Given this list of marker genes ATP1B2 (NCBI Gene Id 482), DLG1, MIR103A1 (microRNA 103a-1), ATP1B3, STK39, MIR26A1, MIR30D, ANK2, ATP1B1, here is a description of the gene set: Human Gene Set: GOBP_REGULATION_OF_POTASSIUM_ION_IMPORT species: Homo sapiens Any process that modulates the frequency, rate or extent of potassium ion import.